Given this list of marker genes IL7, DAZAP2, RNF114, AIM2, SSPN, SIGLEC1, PSMA2, WWC3, HLA-DMB, CENPJ, GCSAM, KARS1, GLRX, TSGA10, DBF4, ALDH1A1, CNIH4, HLA-DQB1, PYHIN1, RBM27, APOL4, C1RL, IFI44L, ST3GAL5 (NCBI Gene Id 8869), SNRPC, GBP4, IL31RA, C1S, PDE6B, GPR85, SERPINA1, LAP3 (leucine aminopeptidase 3), CASP4, ZCCHC14, CUL1, TBC1D2B, OR7E8P, PECAM1, LRRK2, FCGR2A, PDE7A, PRR5L, CD40, AGPAT5, CTNNBL1, GCH1, MYO1G, C1QA, ME1, IFITM2, ZNFX1, STAT3, MTO1, PARP11, SNX16 (sorting nexin 16), TYRP1, C1R (complement C1r), HLA-DQB2, OR51B2, LGALS3BP, FBXO6, CRK, C1QB, GRAP, STAT2, FPR2, GEMIN5 (gem nuclear organelle associated protein 5), SUCNR1, LYG1, ST8SIA4, FMR1, SPATA1, TRANK1, BATF, IFITM3, IL15, CIBAR1P1, PARP14, SLC25A30, SNX10, JAK3, HLA-DQA1, GBP5, PAK1, AKAP7, NHLRC3, HSD11B1, ORAI2, PLA2G4A, APOL6, RNF20, GPR160, GSTK1, FRMD3, DAPP1, HELB, CD38 (NCBI Gene Id 952), TAF1A, KCNJ15, TCN2, C5orf15, HLA-DOA, NAMPT, GRIN3A, PRLR, OAS2, CISH, BTN2A3P, APOL3, SP110, RGL1, CASP1, DPYD, PSTPIP2, TFIP11, ZNF496, CIMAP1B, SOCS3, ANKRD29, SETBP1, ATG3, GIMAP4, NLRC5, TNF, C1QC (NCBI Gene Id 90369), CRLF3, IFIT2, NUP58, PSME1, CD74, PLAAT4, ZNF532, ZNF79, HLA-DPB1, ZNF337, ZNF562, PNKD, WDR48, SNTB2, TMEM150B, CIBAR1, CD209, JAK2 (NCBI Gene Id 3717), STAT1, RSAD2, HLA-DRA, CD72, CSRNP2, CYP51A1, HAPLN3, P2RY6, SERPING1, TRIM61, TBCEL, SLC25A19, MED13L, CD47, DTNB, XRN1, OLFML3, TMEM74B, LEPROTL1, PHACTR2, CGAS, SMARCD3, IFIT1, FBXL5, FZD2, SECTM1, ANKRD44, GRAMD1B (GRAM domain containing 1B), POLR2B, CCDC69, IFIH1, EPSTI1, NUB1, BTN2A2, IFI35, TRIM69, SLFN11, UBB, CASP7, IGFLR1, IL12RB1, LGMN, ZNF672, IL2RA, FHAD1, IFT57, IGFBP4, DDX60, PDCD1LG2, HIVEP2, HLA-DPB2, SETDB2, TLE4, TNFSF10, LIMD1-AS1, DCAF7, here is a description of the gene set: Genes down-regulated in CD4: FOXP3+ T reg versus FOXP3 knockout T reg precursor. studied in species Homo sapiens Regulatory T (Treg) cells, whose identity and function are defined by the transcription factor Foxp3, are indispensable for immune homeostasis. It is unclear whether Foxp3 exerts its Treg lineage specification function through active modification of the chromatin landscape and establishment of new enhancers or by exploiting a pre-existing enhancer landscape. Analysis of the chromatin accessibility of Foxp3-bound enhancers in Treg and Foxp3-negative T cells showed that Foxp3 was bound overwhelmingly to pre-accessible enhancers occupied by its cofactors in precursor cells or a structurally related predecessor. Furthermore, the bulk of Foxp3-bound Treg cell enhancers inaccessible in Foxp3- CD4+ cells became accessible upon T cell receptor activation prior to Foxp3 expression with only a small subset associated with several functionally important genes being exclusively Treg cell-specific. Thus, in a late cellular differentiation process Foxp3 defines Treg cell functionality in an “opportunistic” manner by largely exploiting the preformed enhancer network instead of establishing a new enhancer landscape. from publication Samstein RM, Arvey A, Josefowicz SZ, Peng X, Reynolds A, Sandstrom R, Neph S, Sabo P, Kim JM, Liao W, Li MO, Leslie C, Stamatoyannopoulos JA, Rudensky AY (PMID 23021222) Human Gene Set: GSE40685_TREG_VS_FOXP3_KO_TREG_PRECURSOR_DN